Given this list of marker genes EIF2S1 (eukaryotic translation initiation factor 2 subunit alpha), 5S rRNA, RPL27, 18S rRNA, EIF3M, RPL23, RPL3L, EIF2B5, RPL35A, RPS18, EIF4A1, RPL39, EIF3D (NCBI Gene Id 8664), RPL34, RPS26, RPL5, EIF3J, RPSA, EIF2S3, RPL21 (ribosomal protein L21), RPL37A, RPS8, RPL18A, RPL13 (NCBI Gene Id 6137), EIF3L, RPL39L, RPL29, EIF4A2, RPL4, RPS4Y1, RPS14, RPL31, EIF2B3, RPL9, EIF2S2, RPLP0, RPS5, RPLP1, RPS4Y2, RPL10A, RPL41, RPL6, RPS19, RPL22 (ribosomal protein L22), RPL8, EIF4H, EIF5, RPS13, RPL37, RPL10, PABPC1, RPS25, RPS27 (NCBI Gene Id 6232), EIF4B, EIF4EBP1, RPL14, RPS15, EIF2B4, RPL30, RPL24, RPS28, EIF3A, RPL7 (ribosomal protein L7), RPL36AL, RPS10, RPL12, 28S rRNA, RPL32, EIF1AX, 5.8S rRNA, RPS3, RPS2, RPL11, EIF3C, RPL26L1, RPS16 (NCBI Gene Id 6217), RPL17, RPL13A, RPL26, EIF3B (eukaryotic translation initiation factor 3 subunit B), RPL10L (ribosomal protein L10 like), RPL3, EIF3F, RPS6, RPL7A, RPL27A, RPS24, RPS29, UBA52, RPL36A, EIF3I, RPS4X, EIF4E, RPS27L, RPS11, RPS12, RPLP2, RPS27A, RPL22L1, RPS17, RPL38, EIF3G, RPL35, RPL19, RPS21, RPL18, EIF3K (NCBI Gene Id 55373), RPS9, RPL28, EIF4G1, RPL36, RPS3A, EIF3E, RPS7, EIF2B2 (eukaryotic translation initiation factor 2B subunit beta), FAU, EIF3H, RPL15, EIF2B1, RPL23A, RPS23, EIF5B, RPS15A, RPS20, here is a description of the gene set: Reactome Pathway: Cap-dependent Translation Initiation species: Homo sapiens part of: Eukaryotic Translation Initiation Translation initiation is a complex process in which the Met-tRNAi initiator, 40S, and 60S ribosomal subunits are assembled by eukaryotic initiation factors (eIFs) into an 80S ribosome at the start codon of an mRNA. The basic mechanism for this process can be described as a series of five steps: 1) formation of a pool of free 40S subunits, 2) formation of the ternary complex (Met-tRNAi/eIF2/GTP), and subsequently, the 43S complex (comprising the 40S subunit, Met-tRNAi/eIF2/GTP, eIF3 and eIF1A), 3) activation of the mRNA upon binding of the cap-binding complex eIF4F, and factors eIF4A, eIF4B and eIF4H, with subsequent binding to the 43S complex, 4) ribosomal scanning and start codon recognition, and 5) GTP hydrolysis and joining of the 60S ribosomal subunit.